Given this list of marker genes TEX15, SHOC1, SPATA22, RNF212, STAG3 (NCBI Gene Id 10734), KASH5, here is a description of the gene set: species: Homo sapiens Spermatocyte maturation arrest A type of spermatogenesis maturation arrest in which the block of developmental occurs in the spermatocyte stage. Testicular histology shows seminiferous tubules with Sertoli cells, spermatogonial cells and spermatocytes but no further differentiated cells like round spermatids. Human Gene Set: HP_SPERMATOCYTE_MATURATION_ARREST